Given this list of marker genes ODC1, KIAA0753, KIAA0586, CSPP1, TMEM216, INPP5E, RAC1, here is a description of the gene set: Defective development of the vermis of cerebellum. Dysgenesis of the cerebellar vermis species: Homo sapiens Human Gene Set: HP_DYSGENESIS_OF_THE_CEREBELLAR_VERMIS